Given this list of marker genes SH3BGRL, PIGH, VPS26B, ZDHHC6, ADIPOR1, EFCAB14, NUP85, ZCCHC9, XPO7, HAGH, TRIP12, MTRF1, MSL3, STMP1, MKRN1, RAB11FIP1, ZMPSTE24, ATP13A3, ATG2B, PAIP2, GNAS, ZNF131, DENND2D, NUP107, TM6SF1, SLC6A6, FBXL5, SPOPL (speckle type BTB/POZ protein like), MPHOSPH6, SDCCAG8, CHD1, MAN1A2, TASOR, GRK3, LYPLAL1, CHPF2, FBXW2, LPCAT1, CCSAP, AFG2B, OSBPL11, OSBPL8 (oxysterol binding protein like 8), NLRC4, NUP133, CCDC186, SERAC1, ADI1, SERINC3, LYSET (lysosomal enzyme trafficking factor), CCNH, MAN2B2, PPP3CA, TTC5, NCOA1, HAT1, UBAC2, WDR37, PRKD3, EML4, TAPT1, SRP14, PBX3 (PBX homeobox 3, NCBI Gene Id 5090), KDM3B, RP9, ZBTB1, KMO, HECA, GAS2L3, MEGF9, MTMR6, CUTC, RIOK2, THBS1, ADAM9, GABARAPL2, CBFB, ZNF23, DOCK5, OLR1 (oxidized low density lipoprotein receptor 1), GBA2, DNAJC5, CHD2, SECISBP2L, ZNF470, RALGAPA2, SLC19A2, TMEM170B, PELI2 (NCBI Gene Id 93480), PLPP3, ATRAID (NCBI Gene Id 51656), HMGN1, ETFB, NRIP1, GAPT, CHST7, MILR1, GPR160, SLC9A6, ZMYND11, APBB3, CSGALNACT2, ACAD8, PCGF6, PYGL, NRP1, TMEM14C, PKD2, ZFP36L1, HSD17B4, DPY30, CDC40, GMPR2, TMCO3, GALNT1, KLHL9, LEPROT, ZBED5, ITGB1, SLC35D1, MAPK9, PTGER2, IL1B, FH, PDK1, NDUFA8, CRACR2B, WBP11, DCAF12, CUL3, NFAT5, DENND4C, H2AZ2, ETFRF1, PROS1, CARD8, MFAP3, TPST1, CNOT6L, RUNX1, FLT1, C2CD2, UBE2E3, RAB4A, NORAD, SPSB2, TSG101, CPQ, ZNF45, CAMSAP2, CCDC14, PLEKHM3, GLCE, TRMT61B, MED30, C1orf162, DCTD, H3C7, HMGB1, BOD1L1, HUS1, TCF7L2, DNAAF2, HAUS1, GOLM2, DDX17, XPO4, CALML4, GZF1, UBE3A, PRPF6, ZZEF1, TRAK2, PCTP, AGO2, WRNIP1, DENND11, DNAJB14, PAXBP1, ZC3H13, RO60, PJA1, MAPK1, NEAT1, GNG12, MMGT1, ZNF518B, CEP170, PINK1, KYNU, DESI2, TUBG1, RWDD4, LBR, CYFIP1, HDAC2, TUG1, PCM1, ITGB3, SH3KBP1, here is a description of the gene set: species: Homo sapiens from publication Johnson EN, Appelbaum ER, Carpenter DC, Cox RF, Disa J, Foley JJ, Ghosh SK, Naselsky DP, Pullen MA, Sarau HM, Scheff SR, Steplewski KM, Zaks-Zilberman M, Aiyar N (PMID 15585845) Effects of Neuromedin-U on gene expression in mouse D10.G4.1 T-cells natively expressing the GPCR Axor13 Genes down-regulated in D10.G4.1 T cell line (6h): control versus treated with NMU. Human Gene Set: GSE1791_CTRL_VS_NEUROMEDINU_IN_T_CELL_LINE_6H_DN